The following is a description of a gene set: from publication Fan X, Dong J, Zhong S, Wei Y, Wu Q, Yan L, Yong J, Sun L, Wang X, Zhao Y, Wang W, Yan J, Wang X, Qiao J, Tang F (PMID 29867213) Human Gene Set: FAN_EMBRYONIC_CTX_BRAIN_NAIVE_LIKE_T_CELL species: Homo sapiens, and this is the list of marker genes: PRKCQ-AS1, PRKCH, LEPROTL1, GPR171, IL2RG, CYFIP2, ACTN1, TES, NPM1, CHI3L2, RCAN3, LRRFIP1, STK17B, OXNAD1 (oxidoreductase NAD binding domain containing 1), NSMCE1, STK4, TRAT1, MTERF4 (NCBI Gene Id 130916), CD40LG, TESPA1, LCK, GSTK1, JAML, SEPTIN9, SATB1, PDCD4, SCML4, PRMT2, RRN3P1 (RRN3 pseudogene 1, NCBI Gene Id 94431), ARHGAP15, CDC42SE2, RAC2, TNFAIP3, TMEM123, CD2, PSMB8, SYTL1, CD3D, IL32, TUBA4A (NCBI Gene Id 93373), FAM107B, GBP2, CD48, CCR7, PLAAT4, ACAP1, TOB1, GMFG, IL16, PTPRCAP, ICOS, RGCC, CD52, CYTIP, TRAF3IP3, HLA-F, THEMIS, FXYD5, CIB1, BTN3A2, MYL12A, CD96, LDHB, SEPTIN6, SAMD3, FLT3LG, RHOH, RIPOR2, ABRACL, ZAP70, CD27, IFITM1, PCMTD2, FGD3, CD69, TSTD1, TNFAIP8, SKAP1, IL27RA, GIMAP7, ICAM3, ARHGEF1, MYC, LSP1, TAGLN2, LRRN3, SERINC5, CD3E, HLA-B, ETS1, IL7R, SELL, HLA-C, MCUB, CCND3, ARHGDIB, TSC22D3, LY9, ARL4C, LPIN1, LEF1, TLE5, EPHX2, PVRIG, ISG20, CRIP1, CLEC2D, CNN2, CD3G, LINC00861, RSL24D1, LAT, CORO1A, CAMK4, LTB, LIME1, PIK3IP1, PTPRC, ANXA1, C16orf54, SH2D1A, CD7, FAM117B, HLA-A, LIMD2, EEF1D, PSMB9, TC2N, SMC4, GIMAP4, ID3, NOSIP, CD44, TBC1D10C, TCF7, PIM2, TXK, RPL13A, TXNIP, ADD3, ITK, OCIAD2, APRT, TRABD2A, LDLRAP1, CD6, FCMR, CXCR4, DENND2D, MAL, EMP3, SEPTIN1, PLAC8, GPSM3, STK38, CD5, HPGD, DGKA